Given this list of marker genes DEPTOR, RPS6KB1, PDK1, MAP2K2, RPTOR, PTEN, TSC1, BRAF, GRB2 (growth factor receptor bound protein 2), MTOR, AKT3, PARP1, MAP2K1, MAPKAP1, PRR5L, RAF1, TSC2, PIK3CA, KRAS, AR, AKT1, MAPK1, PARP2, NRAS, MAPK3, SOS2, EIF4EBP1, PIK3R1, INPP4B, SOS1, HRAS, ARAF, RICTOR, TELO2, AKT2, AKT1S1, MLST8, IRS1, here is a description of the gene set: Human Gene Set: WP_TARGETED_AGENTS_IN_TRIPLE_NEGATIVE_BREAST_CANCER Targeted agents in triple negative breast cancer studied in species Homo sapiens